Given this list of marker genes Smad6, Pbrm1, Notch1, Hey2, Vegfa, here is a description of the gene set: The process whose specific outcome is the progression of a cardiac vascular smooth muscle cell over time, from its formation to the mature state. studied in species Mus musculus Mouse Gene Set: GOBP_CARDIAC_VASCULAR_SMOOTH_MUSCLE_CELL_DEVELOPMENT